The following is a description of a gene set: Nucleotide-binding domain, leucine rich repeat containing receptor (NLR) signaling pathways Mouse Gene Set: REACTOME_NUCLEOTIDE_BINDING_DOMAIN_LEUCINE_RICH_REPEAT_CONTAINING_RECEPTOR_NLR_SIGNALING_PATHWAYS studied in species Mus musculus, and this is the list of marker genes: Ripk2, Tab2, Cyld, Tab1, Mapk14, Casp8, Mapk12, Ubb, Ube2n, Panx1, Tnfaip3, Bcl2, Pycard, Nlrp1a, Rps27a, Uba52rt, Pstpip1, Itch, Ubc (NCBI Gene Id 77003), Birc2, Mapk13, Txnip, Birc3, Sugt1, Nod1, Tab3, Txn1, Hsp90ab1, Casp1, Aim2, P2rx7, Traf6, Ube2v1, Mapk11, Bcl2l1, Aamp, Casp9, Casp2, Nlrp3, Map3k7, Nod2, Ikbkg, Casp4, Map2k6, Uba52, Mefv